The following is a description of a gene set: part of: PI3K/AKT Signaling in Cancer studied in species Homo sapiens Loss-of-function mutations affecting the phosphatase domain of PTEN are frequently found in sporadic cancers, as well as in PTEN hamartoma tumor syndromes (PHTS). PTEN can also be inactivated by gene deletion or epigenetic silencing, or indirectly by overexpression of microRNAs that target PTEN mRNA. Cells with deficient PTEN function have increased levels of PIP3, and therefore increased AKT activity. For a recent review, please refer to Hollander et al. 2011. Reactome Pathway: PTEN Loss of Function in Cancer, and this is the list of marker genes: PTEN